The following is a description of a gene set: species: Mus musculus Mouse Gene Set: chrXE1, and this is the list of marker genes: Gm16373, Gm14921, Gm4914, Ube2dnl2, Gm7429, Gm14900, Gm26108, Gm5863, Rps6ka6, Gm4913, Gm14894, Chm, Gm14886, Pabpc5, Gm14903, Gm14895, Gm7134, Gm6418, Gm7405, Gm5942, Gm7416, Gm6429, Gm14926, Gm14913, Gm7340, Gm10112, Cpxcr1, Gm4915 (predicted gene 4915), Pof1b, Gm14936, Gm6491, Gm6427, Gm14898, Gm14896, Tex16, Gm9225, Hdx, Gm26182, Gm24624, Gm7485, Gm14911, Gm27414, Gm1866, Gm7146, Gm6335, Mir361, 2010106E10Rik, Pou3f4, Dach2, Gm14907, Klhl4, Gm14908, Apool, Gm14914, Gm14928, Gm16420, Ube2dnl1, Gm14912, Gm14904, Satl1, H2ab2, Gm14938, Gm6461, Gm24831, Gm6500, Gm5943, Tgif2lx1, Cylc1, Tgif2lx2 (NCBI Gene Id 100039551), Gm14917, Gm14910, Gm5944, 4930555B12Rik, Gm23985, Gm5393, Zfp711, H2ab1